The following is a description of a gene set: from publication Yevshin I, Sharipov R, Kolmykov S, Kondrakhin Y, Kolpakov F (PMID 30445619) Mouse Gene Set: CTNNB1_TARGET_GENES species: Mus musculus Genes containing one or more binding sites for (Ctnnb1) in their promoter regions (TSS -1000,+100 bp) as identified by GTRD version 20.06 ChIP-seq harmonization., and this is the list of marker genes: Brd3, 2810407A14Rik, Gm17171, Cuedc1, Hoxa9, Mir367, Nabp2, Mir6420, Atg9b, Mcm6, Gm16701, Bdkrb1, Gm10039, Tbcd, Dpm1, Gm15564, Appl2, Or2ab1 (NCBI Gene Id 257892), Vwa5b1, Uba3, Mir3061, Or9s13, mt-Tl2, Rgs12, Cdyl, Slc26a4, 5730596B20Rik, Gm12295, Msgn1, mt-Nd2, Mir6236, Lama2, Trbv31, Polr1b, Fntb, Gm8357, Stat3, Atrnl1, mt-Tv, Gm20630, Pef1, Lifr, Or6h1-ps1, mt-Tw, Gm29065, Smim3, Polr2c, Zfp36l1-ps, Sec61bl (SEC61 translocon subunit beta like), Gm567, Zmynd12, Ankmy1 (ankyrin repeat and MYND domain containing 1), Lcn8, mt-Ts2, Lhfpl2, Trpm8, Gm40038, Krtap6-2, Fndc7, Rnf41, Nktr, A930012L18Rik, Smad4, Baalc, Kmt2c, Smad3, T, T2, Bcs1l, Slco5a1, Gm13658, Prkar1b, Serpina3h, Pctp, Zfp998, mt-Cytb, Slc39a14, Glis3, Npm3-ps1, Pdpk1, Duxf1, Sfi1, Mfsd11, Gm13790, Fgfr1, Gm15722, mt-Rnr2, Ighv1-3 (immunoglobulin heavy variable V1-3), Oit3, Rapgef3, Sp5, Churc1, mt-Te, Ctsl, Slc27a5, Mir302d, Gm5370 (predicted gene 5370), mt-Nd5, Mgat4a, Nfkbil1, Gm5532, Gm13608, Ufd1, Lipt1, Gm15889, Bmp8b, Dzip1, Zfp39, Zdhhc19, Muc2, Trmt44, Gabbr1, Defb44-ps, mt-Th, Spata31e2, 2900052L18Rik, Hgfac, Gm8883, Lef1, Adamtsl4, Gm16142, Mroh2a, Ptk7, Gm20788, Nr6a1, Cyb5r4, Septin4, Gad2, mt-Co1, Zfp292, Gm16116, Eddm3b, Pip4k2b, Wnt6, Hmgb2, Ccn2, Gm15779, Kcnh2, Hyal5, Mir302a, Spmip2, Stra6, Dram1, Fam107b, Gng10, Pla2g2a, Mir302c, Bcas3os2, Alg9, Gm25506, Prkag2, Gm11399, 3110070M22Rik, Adsl, Tnks2, Mir7b, Anpep, Furin, A730013G03Rik, mt-Ti, Sult2a5, Irak2, Axin2, Ift70b, Nav3 (neuron navigator 3), Ndufa8, Stk31, Sgms1, Gm11909 (predicted gene 11909), Cdpf1, 2610021A01Rik (NCBI Gene Id 75412), Adgrv1, Notch1, Prex1, Mir30a, Jade1, Hspb2, Gm25656, mt-Tp, Gm12257, Gm9758, Limch1, Gm2453, mt-Tq, Sulf1, mt-Nd6, AW822252, Boll, Cacng2, Gpld1, Atp6v1g2, Gm22863, Prlr, mt-Nd1, Zfp428, Cp, mt-Tm, mt-Ta, Mmp24, Evx1os, Pvalb, Scn5a, Cyp2d41-ps, Eps8, Amotl2, mt-Tt, Kcnmb2, Gm4760, Mpc2, Mast2, Usf2, Fam89b, mt-Tl1, Gas2l3, Cdx1, Btla, D630024D03Rik, Mir302b, Fbxo11, Or5ak23, Por, Krt86, Zfp142, Lepr, Gm19863, Slc2a13, Runx2os2, Gm10463, Gm4861, Gm5641, Gna14